Given this list of marker genes CFAP45, CFAP144, CFAP77, CFAP276, CFAP126, SPMIP10, CFAP52, TEKTL1 (NCBI Gene Id 126402), CFAP20, CFAP90, ENKUR, CFAP210 (NCBI Gene Id 129881, cilia and flagella associated protein 210), PACRG, here is a description of the gene set: species: Homo sapiens Human Gene Set: GOCC_AXONEMAL_B_TUBULE_INNER_SHEATH A structural network of microtubule inner proteins (MIPs) located inside the lumen of the B tubule of the axonemal microtubule doublet that helps stabilize the B tubule.